Given this list of marker genes TMED4, RBM12B-DT, LRRC37A5P, DYNLT2, KAT7, USP30, TATDN3, C17orf67, HSPE1, GOLGA1 (NCBI Gene Id 2800), TAF7, RBM39, ZNF736, WDR43, SERP1 (stress associated endoplasmic reticulum protein 1), MT-TI, HSPA4, TSN, RETSAT, SCAF1, DNPEP, ESF1, DNM1L (NCBI Gene Id 692222), TMED10, METTL25 (methyltransferase like 25), CDC73, ZNF213, HMGCS1, COMMD2, TRMT2A, ITFG2, LAPTM4A, RPL3, SLC11A2, NSD3, DELE1 (DAP3 binding cell death enhancer 1), BORCS8, DGCR8, MTOR, TP53TG1, UBE3C, USP8, EIF3F, NOL12, PROCA1, SOS1, FBXO5, DDX59 (NCBI Gene Id 83479), HDHD5, PNPLA8, BOD1L1, NUF2, MBTPS1-DT (NCBI Gene Id 119863866), GALNT7-DT, RPL22L1, TAF4, ZC3H4, MSH6, DNAJC27, RNU7-27P, IREB2, IGHMBP2, ARHGAP1, ATG14 (autophagy related 14), SGO2, ZZZ3, ERI3, MTIF2, PLEKHA8, OSER1-DT, ZNF592, CEP290, CWC27, TIGD6, TCTA, MOAP1, TEX14, DDX19A-DT, NDUFC2, MAGOHB (mago homolog B, exon junction complex subunit), ZBTB25, EIF1AD, OSER1, DNAJB4 (DnaJ heat shock protein family (Hsp40) member B4), FAM120AOS, LPGAT1-AS1, ZNF835, PSCA, NUP107-DT, RUBCN, PATJ-DT, CDCA7, SRRM2, RRM2B, PTPN11, LPGAT1, CERS2, SSU72, RAP1GDS1, LSM5, UBE2D3, ZNF92, PTPMT1, ANKMY1, WDR11-DT, MRPL57, LIPT2-AS1, RMDN1, BAG5, SON, NEU3, CYP51A1, WDR26, NME1-NME2, SLC35A3, EIF2D, SYNPR (synaptoporin, NCBI Gene Id 132204), PSMD2, UPF1, GGPS1, RNA5SP21, NDUFV2, PSTK, DIS3L, HERC3, ATG2A, HUS1, MOB4, CDC25A, PDXK (pyridoxal kinase), KCTD3, DCUN1D1, BIVM (basic, immunoglobulin-like variable motif containing), HNRNPA3, POR, UIMC1, JTB, WDR45B, MRPS15, METTL16, RPL7A, MRPL13, PDE4A, TMEM165, FAIM, STX18, NOL8 (NCBI Gene Id 55035), PANK4, NSD1, RTEL1, HELQ, EWSR1, NFATC3, FAM98B, POLK, MSL2, RPL14, DICER1-AS1, PPP4R1, CDK2AP1, SKP1, CCZ1P1, BUD23, WWTR1, HMGB1, DOCK7-DT, C12orf76 (NCBI Gene Id 400073), RNF34, AP3S2, LTV1, SNTB2, TBC1D19 (NCBI Gene Id 55296), FRS2, SMURF2, PIERCE1, CROT, FOXK2, LINC03052, DNPEP-AS1, COMMD10, LINC01970, HTR7P1, PSMC6, UBE2Q1, PPIG, PAN3, ATXN7, LYPLAL1, LUC7L3, INTS5, CLUAP1, TTC3, TINF2, XPO4, TACO1, C1orf53, ZNF561-AS1, TOP2B, BCL9, HMGN1, NDUFAF4P1, CIZ1, MRPL53, ZNF32, CDC16, RCBTB2, ARHGEF7, LTO1, VPS37A, TMEM44-AS1, SAMD15, GABPB1 (GA binding protein transcription factor subunit beta 1), MTA3, TARS3, TMEM101, NKAP, G2E3, TMEM109-DT, PPP4R3B, SMAD5, VTI1A, GPD1L (NCBI Gene Id 23171), CCDC40, RN7SL1, HSPH1, DNAJC27-AS1, TNRC18, AAK1, P3H4, RNF103-CHMP3, AGK, AZIN1, DLL1, KRT8P12, CLTA, RPL9, XPC, C10orf88, VPS35, REEP3, FAM76A, GPN2 (NCBI Gene Id 54707), RFX1, GTF3C3, MAGI2-AS3, C2orf42, MARK4, PRRG2, ENSG00000267024, C1orf122, XRN1, MARK1, ZBTB4, ZNF714, LINC01301, KYAT1, HSPD1, ITGB3BP, SLC4A1AP, R3HDM2-DT, NDST2, FBXO21, CDC5L, RBM33-DT, DPY19L2P3, CDK13, PEX3 (NCBI Gene Id 8504), SMG5, RPS6, ZMPSTE24, GALK2, CPSF1, NOA1, HMGXB3, MGME1, SUGP1 (NCBI Gene Id 57794), TOP3B, RAB30, DPP3, STK16, MRPS16, E2F4, EIF5, PPCDC, SRSF11, ECE2, TMCC1-DT, CCDC187, RN7SKP175, ABCB8 (ATP binding cassette subfamily B member 8), SMG8, PRKAR1A, GCH1, BPTF, ABHD13, ZDHHC6, GPLD1 (NCBI Gene Id 2822), NOSIP, CUL5, ZNF260, ZNF174, COA6, SRRT (serrate, RNA effector molecule), MBIP, TULP3, RIBC1, ZFP30, CCT6A, LYSET (lysosomal enzyme trafficking factor), MRPL1, VRK2, NUDT2, BRD9, RSRC1, UBAP2L, RLF (RLF zinc finger), NIPAL2, FRA10AC1 (NCBI Gene Id 57208), NCOA4 (nuclear receptor coactivator 4), REEP5, FZD6, CSTF2T, FZD1, CFAP70, INTS14, SREK1IP1, SLC22A5, SLC24A1, ZNF12, COPS7B, NAA60, CELF1, CA13, RNF4, MTMR9, ERV3-1, PSMA1, ZNF639 (zinc finger protein 639), TUBD1, DUSP28, CNBD2, SIL1, DMAP1, ATP13A4, HSD17B12, TAF12, ENSG00000255326, GTPBP10, ZKSCAN8, DTWD1, RBM41, TRMT1, RANBP1, IFT56, WASF1, RPL21 (ribosomal protein L21), FAM217B, MPPE1, CARS2, ANAPC5, UBR5-DT, RNA5SP473, ZZEF1, BOD1, YTHDF3, SEPTIN2, RHOQ, DCUN1D3, INTS2 (integrator complex subunit 2), STXBP4, MATCAP2, STX16, CSTPP1, SLC7A6, ZNF398, RPL17-C18orf32, ZNF786 (zinc finger protein 786), CDC27, GNAS, ARIH1, ZKSCAN2 (zinc finger with KRAB and SCAN domains 2), CAMKMT, SEC24B, MAML1, DCAF8, NGRN, CCDC112, PIGL, MRPL16, ITPRID2, FER, RBM14-RBM4, SMNDC1, ALG9, HECTD1, TMCO1-AS1, SH2B1, TSSC4, ZFAND5, DHX30 (NCBI Gene Id 22907), NOL11, SHOC2, SNORD12C, ORC5, RPL23A, MAU2, MADCAM1, RPS7, NIPSNAP2, NCL, ENSG00000265055, BRD2, ARHGAP19, AHSA2P, MST1P2, ANKRD39, TEDC1, HACD3 (3-hydroxyacyl-CoA dehydratase 3), ALKBH3 (NCBI Gene Id 221120), TMEM69, TNPO3, EIF2B4, NSFL1C, ENSG00000260136, TPI1P2, YLPM1, VAMP4, KCTD18, COA5, CPSF7, VCP, LIMD1-AS1, TBC1D16, HDAC4-AS1, SLC25A3, ANKRD40, ZBTB8OS, ZNF14, SCLY, TATDN2, ZNF207, RPL32, ANKAR, NCOA7, DTD1, LINC01852, RPP38, TFAM, ZNF273, EFCAB7, FBXO11, RHNO1, TMED8, NMT1, ZFX, CTBP1, FAM228B, SPCS2, CRTC2, RRM2, TUFM, SUPT16H, COG4, MORN4, HCG14, HDAC8, ZNF721, MAP4K5, TBC1D2, RPL21P122, MRPS22, C10orf143, SMARCA5 (SWI/SNF related, matrix associated, actin dependent regulator of chromatin, subfamily a, member 5, NCBI Gene Id 8467), ARHGAP21, CCDC97, TRUB2, ALG10B, SDE2, ITPRID2-DT, TEFM, PSMD5, NCOA5, NHLRC2, SELENOH, RITA1, CHCHD2, ANKRD46, DPP3-DT, DIS3L-AS1, ARL2BP, RAB18, STX16-NPEPL1, PCNP, HAND2-AS1, WDR82, ERCC6L2, POLR2H, IQGAP3, QRICH1, TCTN1, MAN2C1, TOMM20, ANKRD23, CEP162, NCBP3, LINC01023, HDGF, PDCD2, NNT, DNMT3A, LYRM9, NDUFAF3, KLC2, PSMA3, TVP23B, RPL37, PSMC2, TMCC1, SLC35D1, ZNF197, B4GALT7, AVL9, GRPEL2, ACTG1, WWP2, SEC24B-AS1, SPACA9, COX16, BMS1, SMARCE1, CHPF, VHL, JMJD4 (NCBI Gene Id 65094), USP47, ZNF195, AFF4, ZFC3H1, LRP11, RO60, IAH1, ANKRD13D, SMARCA4, MED22, ENOX2, H2AX, LSM14A, USP42, ATPAF1, ARIH2, TBX2-AS1, TTC8, IQSEC1, FAM120A, SEPHS1, C1QBP, NNT-AS1, VPS54, SNRNP27, DLD, ZNF862, SMARCD2, KCNJ2, COPB2, SLTM, MIA2, ZBED3-AS1 (NCBI Gene Id 730772), RCC1, ZC3H3, SLC37A1, NAPEPLD, PRCC, RAB7B, PROX1, ERMARD, MIR3936HG, CDCA3, KIAA1549, BMS1P4-AGAP5, SRCAP, VDAC2, FOXM1, UBA5, JAK1, BCKDK, WDR31, DHX33, ZNF337, CARINH, PPP1R35, USP54, GSTCD, NANP, MTARC1, RPL22, DPY19L3 (NCBI Gene Id 147991), ZNF407, BCL2L2-PABPN1, ZNF302, STYXL1, DHRS7, LRP4-AS1, DUX4L18, TBP, MED15, FBXO38, HAPSTR1, FXN, ZKSCAN2-DT, GOLGB1, DBIL5P, LINC03065, KLHL20, SSU72-AS1, PDE6D, EPC1-AS2, LGALS3BP (NCBI Gene Id 3959), EEF1A1, RGS5, BZW1-AS1, PSMD14, PPP4R1L, FAM200B, GVQW3, PPP2R3C, ATP9B, PWP1, SNAPIN, HERPUD2, ERBIN, TCF12, LARP1B, KMT5B, SNRNP70, ZMYND8, KNTC1, CYB561A3, ZNF767P, PAN3-AS1, MIR3913-1, SNRPD1, BAZ1A-AS1, USP37, PHB2, KIAA1191, TRIM52, TRIP13, TTC4, VWA8-AS1, DDX55, MCM3AP, MRPS35-DT, PHLDA3, RNF139-DT (NCBI Gene Id 101927612), NCSTN, PHF3, RPL6, RNF167 (ring finger protein 167), RBBP6, ERP44, BAALC-AS1, SMU1, MRS2, PINK1, MIGA1, FAM3A, COG5, PSPH, FBXW2, SRD5A3-AS1, ESD, NSMAF, PI4KB, B4GALT5, IFT57, SNORD42B, RAB30-DT, MON1A, NBPF1, LINC00552, BANP, MITD1 (NCBI Gene Id 129531), THAP5, CROCCP2, PRKCH, FAM227B, NMNAT1, AURKAIP1, PIP4P2, RNA5SP283, BRWD1, RC3H1-DT, ZNF724, ZFAS1 (NCBI Gene Id 441951), ACYP2, RAN, MIR7155, SUN1, SNHG16, NT5C3A, TXNDC9, MAP3K10, RPS5, POLG, THUMPD3-AS1, COQ4, MRPL33, ZNF354B, ERGIC2, TFPT, DUSP16, TXN2, MAPKAPK5, SNORD59A, REXO5 (NCBI Gene Id 81691), ILF2, SLC25A51, KPNA2, DNAJC25, TRDMT1, YPEL5, PSMF1, CIBAR1-DT, MIDEAS-AS1, STEAP2-AS1, USP1, DNAJB9, LINC01547, PPIL3, RWDD3, KCTD5, POU3F2, PRELID3B, BCAP29, SULT6B1, ENSG00000254718, DHX33-DT, DECR1, TMEM62, ANKFY1, PPP1R35-AS1, WDR73, MPLKIP, MIR199B, RPL12, FAM174A-DT, RANBP17, ZNF581, SRRM2-AS1, EPC1-AS1, IFTAP, LNPEP, PPP4R3A, RPL32P3, PARK7, TLK2, ZNF606, ZNF112, SF3B3, CSE1L-DT, ZNF143, ACVR2A, KDM5C, CHCHD3, YTHDC1 (YTH N6-methyladenosine RNA binding protein C1), JPX, NFKB1, WDR36, KBTBD2, TARBP2 (TARBP2 subunit of RISC loading complex), SRSF10, PPM1A, FAM120B, FBXL13 (F-box and leucine rich repeat protein 13), EXOSC3, RWDD3-DT, TEX38, PAIP1, RPL37A-DT, SNHG3, TM9SF1, ZNF189, YPEL1, RPS6KB1, LZIC, SLC39A9, PIH1D1, EXD2, PHOSPHO2, FBXO22, SNRPB, HYCC2, MIR3154 (microRNA 3154), WDR83OS, WDR11, HIRA, PARD3B, CBX1, ZNF678, C9orf163, ZNF580, AKT1S1, NUP107, METTL8, C18orf21, MYEF2, MRPL4, NUP42, ACSF3, LAMP1, PUM2, MBTPS1, RTTN, TRAF7, CNOT7, CCNJ, CFAP210, INO80D-AS1, MRPL19, ABCC11, RPP38-DT (NCBI Gene Id 221060), CANX, ZNF276, EEF1D, RB1CC1, RBBP5, PCGF3, GALNT16-AS1, KIN, TRERF1, SSBP1, B3GALT9, HSPA9, MRPL58, CPNE1, ARHGEF11, PARP16, MRPL40, AXIN2, MKRN3, RBAK, GPD2, PTRHD1, IMP4, SNORA14B, CDIP1, PSMD7-DT, BORCS8-MEF2B, PYURF, SNX8, DNAJC25-GNG10, RBM28, AGPAT3, ATP11B-DT, PIGG, EEFSEC, COL6A4P1, RNF141, SLC25A36, PEX2, DTWD2, ZNF319, ZGPAT, HDLBP (high density lipoprotein binding protein), NRBP1, RHBDD3, PUS10, UCA1-AS1, WAC, PCBD2, LRRC27, TCERG1, PREPL, NUDT19-DT, SNRPB2, MRPL44 (NCBI Gene Id 65080), ALDH9A1 (NCBI Gene Id 223), COX17, TSPAN31, KLHL9, NDUFS1, RPL37A, CCDC88B, NCOR1, SPATA17, MPC2, COPB2-DT, RPS29P16, LEMD2, EDC4 (NCBI Gene Id 23644), CCAR2, CASD1, NDUFAF1, RUSF1, NFKBIZ, TMCO1, FBXL5, BPNT2, DDX21, TSSK3, ATIC, RIOK2, PCNX4, ZC3HC1, ZNF213-AS1, FASTK, THNSL2 (threonine synthase like 2), JTB-DT, TMEM214, TK2, SLC33A1, ZNF497-AS1, TCF25, ZNF615, ZNF143-AS1, MRPL24, TUG1, KDELR1, NUDT18, LRRK1, ZBED3, NOP16 (NOP16 nucleolar protein), SYPL1, ZNF876P, H3-3B (NCBI Gene Id 3021), SFSWAP, ZNF180, VPS9D1, LANCL1, ELMOD3, PDCD6IP, PMS2P3, ZNF146, ZNF691-DT, POLD2, PLEKHJ1, TGOLN2, LAPTM4A-DT, SDHAF2, OTUB1, DPH7, BLOC1S1, TMEM202-AS1, LRSAM1 (leucine rich repeat and sterile alpha motif containing 1), ANXA4, TMEM79, CAND1, EIF2AK4, NUDCD3, TMEM64, EIF5B, ZNRF2P2, SAE1, CRPPA, PLEKHM3, MRPL50, CPEB3, NDUFC2-KCTD14, ZNF594-DT (NCBI Gene Id 284017), CIAPIN1, TIGD1, GRSF1, UBE2I, MRPL39, FH, SLC25A25, C8orf33, SEPTIN7P13, NAE1, BBS1, PDCD6P1, NME1, DCAKD, DNAJC2, TAS1R1, TOR1AIP1, SAR1B, SMG7, ATP6V1G1, BBIP1, U2SURP, RBM33, THAP2, SF3B2, PRORP, ZNF628-DT, CNOT4, KPNA1, SEC61G, STMN3, KNSTRN, ITSN1, SNX5, COP1-DT, EPS8, ARMC10, MKLN1-AS, ACOT13, ATP5PF, NSMCE4A, ARMH3, TMEM109, BMS1P4, GPX7, AP1S1, EIF3B, MRPS31, ZBTB45, PPP4R3B-DT, TENT2, LRRC8A, EIF4G1, SNX19, WDR83, IMPACT, ABR, MAK16, AKAP7, SEPTIN7P2, ERCC6L2-AS1, TBC1D17, USP40 (ubiquitin specific peptidase 40), CCNL1, NCK2, RINT1, GLB1L, CEBPG, POLG-DT, MRPS31P5, RBIS (ribosomal biogenesis factor), TAF6, PTOV1-AS1, LINC00667, ZNF337-AS1, EXOC8, TTC32, MDH2, SDHC (NCBI Gene Id 6391, succinate dehydrogenase complex subunit C), MAF1, USP14, LINC02875, C1orf43, MT-RNR1, RNF149, SPG7, ZNF785, ANKRA2, WDFY2, SLC27A5, BRD4, TRAM2, ADAM17, ZNF460-AS1, SNAP47, ZFR, MRFAP1P1, EXD3, PCNX4-DT, ZNF689, YJU2, VPS36, MPHOSPH10, RNA5SP134, EFHB, COPS2, PEX13, GABPB1-AS1, CCDC59, ARFGEF2, ISY1, ZMPSTE24-DT, TNIP1, GTF2IP13, PFKM, RBM14, NUP54, DENR, ZNF165, RAD17, TMEM9, IPO7, CRTAP, DDX19A, LYPLAL1-DT, SOX6, NDUFC1, MLST8, TAPT1-AS1, PCM1, PPOX, KIAA0586, MDH1B, KIF2A, KIF18B-DT, PHYKPL, BCAR3, RPL17, NGDN, CBLL1-AS1, OFD1, MTCO1P14, TRPM7, PDCL3, MDM4, UCHL5, TBL2, CDK12, OTUD7B, MRPS18C, CTBP1-DT, IPO4, PIDD1, HSPE1-MOB4 (NCBI Gene Id 100529241), ZAR1L, TSR3, TTBK2, ZNF430, CNPY4, TMEM43, STK35, NRDE2, TARS2, PCID2, STIP1, TMEM242, KIF9-AS1, H2BC26, RPS23, TP53RK-DT, GTPBP3, DBR1, DCP1A, MVK, MAPK14, MTX2, BTF3-DT, PFN4, SEMA4C, MIR762HG, EDF1, MNAT1, NSL1, YIPF4, GGA2, LINC01107, USP7, STEAP2, ZNF10, SUPT7L, UBB, SNORD55, ZNF205, DVL3, INO80B-WBP1 (INO80B-WBP1 readthrough (NMD candidate)), NUP133, EIF4E3, THAP3, PHRF1, RIPOR1, SLC39A6, BZW1, MTBP, UBXN4, SF3A3, HEXD, CHFR, FREM1, DUS4L, FBXO42 (F-box protein 42), TTC32-DT, SRRM1, DTNB, DLAT, NOL9 (NCBI Gene Id 79707), SMIM26, NOL4, ENSG00000260830, STKLD1, HSP90B1, ZNFX1 (zinc finger NFX1-type containing 1), CENPP, MRPL30, BRF1, BTNL12P, JRK, ZBTB26, SEPTIN7-DT, SEC13, HLCS, MGRN1, PPP2R5B, MKRN2, HNRNPC, NINJ2-AS1, SPG11, SWT1, NUP214, CCDC117, RHOB, TUBGCP3, TIMM9 (translocase of inner mitochondrial membrane 9), SNORD1C, NUP133-DT, RUVBL1, MT-TF, SLC44A1, MIR3613, SDHAF3, PRR34, C17orf75, KDM4C, TDP2, TRAM2-AS1, PIH1D2, ACP1, ZNF3, SF3A2, TMTC3, UNC50, TGFBRAP1, REXO4, TARDBP, TMEM248, TSEN15, ZNF579, SETD5, ZNF408, PRDM15, ECPAS, PFDN6, ZCCHC8, CCDC47, DARS1-AS1, NR1H3, NDUFB3, SPPL2A (NCBI Gene Id 84888), MTERF4, CNIH3, SMARCAL1, SGCE, CBLL1, ZNF362, MICOS10-DT, RNF10, USP34-DT, GPBP1L1, GFUS, ANLN, USPL1, PSMD14-DT, TM9SF3, DICER1, LSG1, GOSR1, PEG10, MCMBP, UBQLN2, COG1, RAD51C, MAD2L1-DT, SNORD43, STX18-AS1, NT5C, PHF5A (PHD finger protein 5A), RAD52 (NCBI Gene Id 5893), ASXL1, ZNF280D, ZMYND12, BCL2L2, RFWD3, CCT2, GLUD1P3, ERBIN-DT, ATP2C1, FBXO31, SCNM1, EPM2A-DT, SLC2A4RG, KANSL2, PSMD7, LTBR, TUBGCP5, XRRA1, EEF1B2, ARHGAP19-SLIT1, MAN1A2, FDPS, ZFAND2A, SLC25A11, COA3, ENSG00000266100, LIAS, ARF3, SH2D6, KHNYN, ZNF606-AS1, SENP6, SLX9, ZDHHC4, UBE2D3-AS1 (UBE2D3 antisense RNA 1), PIGP, ZNF628, FYTTD1, ZNF446, SNX10-AS1, MRE11, MIR5696, LRRC40, SNRPA1, BANF1 (barrier to autointegration nuclear assembly factor 1), N6AMT1, MAPKAPK5-AS1, ACSL3, CACYBP (NCBI Gene Id 27101), RBBP4, DMTN, ORC6, PRPF31, DRG2, ANKRD11, ARID1B, HEBP1, ENSG00000268129, BRCA2, CNBP, PBLD, CDH22, ARHGDIA, SF3B6, TMEM18, ACO2, IPO5, ATP9A, ZBTB38, COPS4, USB1 (NCBI Gene Id 79650), ADAP2, METTL15, ZNF879, SNRPG, CFL1P1, ZNF410, RNF139, COQ8A, LINC03072, LYRM1, PSMG3, TAF12-DT, PIGV (NCBI Gene Id 55650), ATP5ME, ZER1, POLR2B, HOXA4, TMEM242-DT, RIC8B, USP24, ENSG00000233230, COPZ1, ZNF346, TRIP4, ZNF544, NSA2, ERI2 (ERI1 exoribonuclease family member 2), NOXA1, RELL2, UBE2C, ALG3, PTCD3, PYCR2, ARID5B, ZSCAN25, ISY1-RAB43, MTR, PSMB7, CLTCL1, GSK3A, STX17, SMC1A, NAA35, DENND6B, OPA1, CAPG, TAF9 (NCBI Gene Id 6880), ZNF569, WDFY3-AS2 (NCBI Gene Id 731216), PPCS, CHD8, WEE2-AS1, BRF2, NT5DC1, TAPT1, TBC1D8, MT-TP, FN3K, IQCB1, ZNF518A, RBM17, ZNF506, AQR, ZNF460, IGFL4, TRA2B, CLPX, CDKN2AIP, ARPP19, CGGBP1, SLC35B3, GPR27, FAM117A, MAGI2, RAB7A, MRPL48, IRAG1-AS1, ELP2, TSR1 (NCBI Gene Id 55720), QSER1, TMEM250, SPIDR, RPS27, SEC22B, DENND1B, MLH1, SPRTN, CCDC57, ETFA, SEPTIN7, MRPL12, SHARPIN, NAIF1, MELTF-AS1, PRANCR, NT5M, ALDH1A3-AS1, MRPL27, EPM2AIP1, DBH, CWC25 (NCBI Gene Id 54883), DRG1, MRPL55, ZSCAN32, TMA16 (NCBI Gene Id 55319), RPLP2, ARHGEF12, ASNSD1 (asparagine synthetase domain containing 1), SNX24, MTDH, MT-TM, ZC3H14, DPY19L4, CDC26, INO80B, MBOAT2 (membrane bound O-acyltransferase domain containing 2), RPS11, MARCHF6, OGFOD3, GAS8, ATRAID, GTF2IP20, TXNL4A, CHRAC1, HDHD5-AS1, MCM4, HNRNPH1, PEMT, PTPN21, MCEE, TMEM138, MANEAL, MARCHF7, RXYLT1, CDK4 (cyclin dependent kinase 4), MARK2, ZNF770, ZNF136, ZNF292, KANSL1, SS18L1, URGCP, UPRT, AKAP1, EMG1, HSPA8, SEC22C, INTS12, UBE2J2, OSCP1, ZNF805, GSAP, ARID4B (AT-rich interaction domain 4B), PPP1R9A, AMOTL2, DUS1L, CUL4A, TOM1, C3orf38, POLG2 (DNA polymerase gamma 2, accessory subunit), SPAG8, H6PD, HNRNPUL1, HAT1, FASTKD2, PSMD3, MTCO3P12, CREBZF, HEXIM2, LAS1L, DOCK7, CHASERR, CCNT2-AS1, THUMPD2, KLC1, ING5, CERT1, LIG4, EMC4, CRTC3, UQCRFS1-DT, PRDM10-DT, ZNF561, ATL1, ZXDC, VPS72, EFCAB2, ENSG00000283078, TMEM203, UBE2V1, ACP2, CDC40, SMG6, SUGCT, AGFG1, AMFR, ITGA7, RBKS, TNPO1-DT, HERPUD2-AS1, RBSN, MIR4492, RPL27A, GTF2IRD1P1 (GTF2I repeat domain containing 1 pseudogene 1), ZFX-AS1, TSPAN10, USF1, SNORA24B, ITFG2-AS1, PSIP1, RC3H2 (NCBI Gene Id 54542), GIPC2, CDK5, GFM2, BAD, ATP5F1B, EAF2, SETD2, TRMU, RNF135, MGAT1, ABCA11P, C11orf58, ARFRP1, SCYL1, TBRG4, COPB1, DSTYK, ATP6V1E2, CNTD1, MRPS2, ATP5MC2, PRPF39-DT, RUSF1-DT, TESK1, RNF19A, SEM1, AKAP9, VWA8 (NCBI Gene Id 23078), EIF4E2, SELENOS (selenoprotein S), RCN2, GABPA, COQ5, MIR5091, FKBP10, ZNF774, PABPN1, HDAC3, CHD1-DT, ENTPD1-AS1, NKTR, TCAF1, MIR4727, HEMK1, SH3YL1, CLK3, MT-ND2, FMO5, TMEM128, GSTA4, ENSG00000232995, SLC30A5, RFXANK, TMPOP2, CIBAR1, NRDC, LSM3, SNRPA1-DT, NAA15, NKAPD1, DCAF6, BTBD10, SRP19, CD276, PRDX1, SNORD58B, SMG7-AS1, PAXIP1, SNORD46, GART, RNF103, COA8, CCDC115, UBA2 (NCBI Gene Id 10054), TRAPPC2, ACAD11 (NCBI Gene Id 84129), MIR4519, RRP15, CBLN3, ZBTB7A, WDR24, TNPO1, UBE2Z, UTP3, ZNF565, RPS19, LINC01264, DCLRE1A, PTER, TSEN2, TMEM41A, FAM53C, FBXO38-DT, KRR1, GOLGA3 (NCBI Gene Id 2802), MRPL21, SCMH1-DT, NUBP1, YBEY, CDK5RAP1, PUF60, OSBPL11, STOML2, ZNF24, ATP1A1-AS1, UQCC6, LIPT2, ZFP64, UBE2D2, THOC7, INHCAP, PIGQ, SENP1, DGKE, NDUFB2, SKA3, ZNF496, POLD3, LINC02939, RBM25, CCDC149, RAD23B (NCBI Gene Id 5887), PSMG3-AS1, MAILR, DHX9, TUT1 (NCBI Gene Id 64852), RCCD1-AS1, PCLAF, KLHDC2, LIMA1, ADAT2, PTPN4, TRMT61B, DCAF17, SLC5A6, GTF3C5, MRPS31P4, DHX36, RPL29, DALRD3, RNU6-92P, FAM133B, UBE3A, GEMIN4, HDAC4, DNAJB12, CFAP410, NDUFS7, GEMIN7, USP22, RWDD1, ZC3HAV1L, PPAN, ADO, RCCD1, GNPTG, GPR137, ZNF570, RNF187, COQ9, MIR191, RBAK-RBAKDN, SNX27 (NCBI Gene Id 81609), ZNF669, ZFAND2A-DT, LINC01441, COA6-AS1, TMEM198, TMBIM6, TMEM209, NPLOC4, MUL1, WDR46, SNORD60, CAT, RPTOR, FTO, SURF4 (NCBI Gene Id 6836), OLA1, PHF8, PTOV1, TPM4, TWSG1-DT, COX11, ACBD6, DDX19B (DEAD-box helicase 19B), ZNF652-AS1, SLC2A8, SZRD1, EAPP, RILPL1, PDIA4, ZNF250, SS18, IPPK, YTHDF2, NR1H2, PSMA7, UTP15, ZNF790, LINC00674, ZNF695, PRPF4, MAP2K2, PCBP2, ABTB1, ENSG00000246792, DNM1, COP1, BCL2L1, ZNF605, EEF1A1P23, OSTC, DDX6, VPS51, C19orf12, here is a description of the gene set: Genes containing one or more binding sites for (ZNF711) in their promoter regions (TSS -1000,+100 bp) as identified by GTRD version 20.06 ChIP-seq harmonization. Human Gene Set: ZNF711_TARGET_GENES from publication Yevshin I, Sharipov R, Kolmykov S, Kondrakhin Y, Kolpakov F (PMID 30445619) studied in species Homo sapiens